Given this list of marker genes ERCC5, SLC36A2, VIPAS39, TDO2, GSS, ERCC3 (NCBI Gene Id 2071), LIPT1, ASPH, FARS2, PCCA (NCBI Gene Id 5095), IVD, ETFA, MCCC2, DMGDH, LETM1, NFU1, GALT, ABCD4, PEX5, SLC6A20, NAGA, ERCC2, BCS1L, SLC25A13, CTH, SLC7A7, HPD, PREPL, IBA57, MT-TN, PCCB, PET100, SURF1, SLC35A1 (NCBI Gene Id 10559), NDUFAF6, MTHFR, TRNT1, UMPS, PRODH, MOCS1, MOCS2, CYP27B1, ACAT1, GPHN, SLC35C1, NADK2, GALE, SLC13A3, COA8, ATPAF2, MTRR (5-methyltetrahydrofolate-homocysteine methyltransferase reductase), TNFRSF11B, SLC2A2, XPC, NEU1, TAT, SLC6A18, DGUOK, NGLY1, SUCLA2, PEX1, AASS, FOCAD, CAMKMT, GUCY2D, PHYKPL, SLC19A2, FAH, FH, DDB2, FTCD, RRM2B (ribonucleotide reductase regulatory TP53 inducible subunit M2B), ETFDH, PAH, SLC7A9, MMACHC, KYNU, HCFC1, DHTKD1, MMADHC, ALDOB, CPS1, GATM (NCBI Gene Id 65211), PRDX1, GCLC, SLC25A15, UQCRB, SLC34A1, HAL, ACADM, CLCN5, CTNS, ASL, MARS1, ALDH5A1, OPLAH, GGT1, SLC6A19, LMBRD1, TNFRSF11A, GEMIN4, GLYCTK, OTC, ALDH4A1, SARDH, SUOX, ATP7B, EHHADH, CLTRN, ARG1, TK2, SPINK5, HIBCH, XPA, ERCC4, ETFB, CYP2R1, ALDH6A1, PLOD2, HGD, VPS33B, SLC3A1, OCRL, GLDC, CASR, MTR, PPM1B, TRPV6, NFS1, HNF4A, AGXT2, SLC1A1, OAT, ASPA (aspartoacylase), CBS, here is a description of the gene set: Abnormal urine amino acid level Human Gene Set: HP_ABNORMAL_URINE_AMINO_ACID_LEVEL studied in species Homo sapiens